The following is a description of a gene set: Mouse Gene Set: GOBP_MESODERM_DEVELOPMENT species: Mus musculus The process whose specific outcome is the progression of the mesoderm over time, from its formation to the mature structure. The mesoderm is the middle germ layer that develops into muscle, bone, cartilage, blood and connective tissue., and this is the list of marker genes: Tcf15, Hnf1a, Ssbp3, Vegfa (vascular endothelial growth factor A), Msgn1, Epb41l5, Gja1, Bmp4, Itga2, Smim43, Zic2, Ctdnep1, Kdm6b, Rps6ka6, T, Chrd, Fendrr, Nckap1, Nanog, Zfp36l1, Mesp2, Tead1, Wnt5a, Itgb1, Six2, Irx3, Nodal, Churc1, Fgfr1, Cited2, Pax2, Ext2, Scx, Taf10, Pou4f1, Acvr1, Acvr2a, Prkar1a, Macf1, Gdf3, Etv2, Ecsit, Itga8, Smad2, Setd2, Foxf1, Pou5f1, Smad4, Zic3, Foxc1, Wnt3a, Eomes, Inhba, Tbx1, Txnrd1 (thioredoxin reductase 1), Bmp7, Twsg1, Armc5, Mesd, Bmpr2, Eya1, Mixl1, Lhx1, Lhx2, Hoxa11, Bmpr1a, Shh, Epha2, Srf, Tbx3, Axin1, Mesp1, Wls, Osr1 (odd-skipped related transcription factor 1), Gdf1, Tbx19, Htt, Pus7, Prkaca, Otx2, Sfrp2, Tead2, Snai1, Nog, Poglut1, Gpi1, Dand5, Fgf8, Smad3, Tcf7l1, Ahdc1, Nr4a3, Amh, Acvr2b, Wnt3, Itga3, Hmga2, Tal1, Nf2, Rpl38, Tbx6, Sall1, Lef1, Foxa2, Smo, Itgb3, Yap1, Ets2, Ppp2ca, Smad1, Ovol1, Wnt11, Pofut2, Tlx2, Dkk1, Palb2, Exoc4, Acvr1b, Apela, Cer1, Hand1, Ext1, Trp63, Itgb4, Foxc2, Kdm6a, Foxh1, Crb2, Dll3, Nup133 (nucleoporin 133)